The following is a description of a gene set: All-trans retinoic acid (RA) induces transforming growth factor beta (TGF-beta)-dependent autocrine growth of mouse embryonic fibroblasts (MEFs). We have used chromatin immunoprecipitation to map 354 RA receptor (RAR) binding loci in MEFs, most of which were similarly occupied by the RAR alpha and RAR gamma receptors. Only a subset of the genes associated with these loci are regulated by RA, among which are several critical components of the TGF-beta pathway. We also show RAR binding to a novel series of target genes involved in cell cycle regulation, transformation, and metastasis, suggesting new pathways by which RA may regulate proliferation and cancer. Few of the RAR binding loci contained consensus direct-repeat (DR)-type elements. The majority comprised either degenerate DRs or no identifiable DRs but anomalously spaced half sites. Furthermore, we identify 462 RAR target loci in embryonic stem (ES) cells and show that their occupancy is cell type specific. Our results also show that differences in the chromatin landscape regulate the accessibility of a subset of more than 700 identified loci to RARs, thus modulating the repertoire of target genes that can be regulated and the biological effects of RA. studied in species Mus musculus Genes bound by RARG and up-regulated by tretinoin (all-trans retinoic acid, ATRA) in MEF cells (embryonic fibroblast). from publication Delacroix L, Moutier E, Altobelli G, Legras S, Poch O, Choukrallah MA, Bertin I, Jost B, Davidson I (PMID 19884340) Mouse Gene Set: DELACROIX_RAR_TARGETS_UP, and this is the list of marker genes: Atp11a, Msln, Esd, Tgfb3 (NCBI Gene Id 21809), Nid1, Aox1, Evx2, Lipe, Mllt6, Tm4sf1, Plekhb1, Cebpb, Fgf18, Mmp2, Dmp1, Nupr1, Prss8, Skil, Chka, Capn5, Stk11, Tyk2, Tnfrsf12a, Zbp1, Blnk, Mrpl34, Mast2, Hmga1, Dusp1, Tcirg1, Dhrs3, Prss22, Fcna, Gsr, Car12, Cp, Tnfrsf11b (NCBI Gene Id 18383), Pgpep1, Rarb, Sat1, Junb (NCBI Gene Id 16477), Inmt, Bhlhe40, Hoxd12, Dusp6, Crabp2, Resf1, Ccn2